The following is a description of a gene set: species: Homo sapiens We investigated at which stage of maturation commitment to a stable Foxp3-expressing phenotype takes place. We assessed stability of Foxp3 expression in thymic Foxp3+ Treg subsets of different maturity, defined by CD24 expression. Next we compared gene expression profiles of Foxp3+ Treg subsets (+) of different maturity (24lo, 24int, 24hi) and could identify a set of genes that were specifically up or downregulated in Foxp3+ Tregs, but not in Foxp3- conventional T cells, in a maturation-dependent manner. Genes up-regulated in CD42 high cells from thymus: T reg versus T conv. from publication Toker A, Engelbert D, Garg G, Polansky JK, Floess S, Miyao T, Baron U, Düber S, Geffers R, Giehr P, Schallenberg S, Kretschmer K, Olek S, Walter J, Weiss S, Hori S, Hamann A, Huehn J (PMID 23420886) Human Gene Set: GSE42021_CD24HI_TREG_VS_CD24HI_TCONV_THYMUS_UP, and this is the list of marker genes: COMMD1, SAMM50, PNPLA2, TMEM179B, EIF3K, MCM10, PPFIA4, MAP3K1 (mitogen-activated protein kinase kinase kinase 1), SENP3, NAXE, ACTB, ANAPC11, NR1H3, PRKAB1, STOML2, NDUFS3, RPP25L, DDX27, SNAPC2, PCSK7, REX1BD, LSR, RAB8A, PRPF31 (NCBI Gene Id 6106), CDC45, FES, NMI, FKBP8, TENM1, LRP1, CIAO1, TMEM126A (transmembrane protein 126A), PLEKHO1, UBXN1, HCN2, LEMD2, SSNA1 (SS nuclear autoantigen 1), ADD1, ASXL1, CDC37, PTCD2, CYBA, GSTT2, SMDT1, HIKESHI, CD52, NFIC, TLE5, RBM42, NLN, ETFB, RING1, SEMA4A, PSEN1, C3AR1, CHD8, UBE4B, GNAS, CAPNS1, MRAS, RGL2, POLR1D, ATP7A, UQCRC1, TP53, HSD17B7, PROM1, TEN1, FABP3, INTS3, ADPRM, LY86, CCR2, ATP5PO, ISYNA1, CDK2AP2, ERP29, REEP5, DYNLL1, IFI30, TPK1, AKT2, PPIB, HRAS, IGFBPL1, HTR1B, MAPK3, MEP1B, DFFA, ECH1, NELFE, PNKP, RPL28, NUBP1, PRKCSH, TAF11, CLTA, RAD50, ALDH3A2, VPS72, FLCN, SLC27A1, C1QB, BUD31 (BUD31 homolog), NCBP2AS2, ECHS1, PEX6, ATP5MG (NCBI Gene Id 10632), STAU1, MAN2B1, AURKAIP1, HOXC5, RPS23, CIDEC, MAF1, COMMD2, ING4, MRPL44, CEP89 (centrosomal protein 89), NDST2, PPP1R14B, RNASEH2A, LRP10, FBXW4, ZFYVE19, MAST3, AMMECR1L, ANGEL2 (NCBI Gene Id 90806), IL16, MKNK2, VAMP8, CEP250, ARHGAP45, RAD1, CSNK1G2, TCF25, EIF3L, PPP1R21, PTS (6-pyruvoyltetrahydropterin synthase), CD93, PDHA1, SMAD5, ARX, EIF2B5, PSMB6, PAFAH1B3, DUS1L, ALDOA, TMEM259, MXD4, MRPL4, HSF1, RPS6KB2, XRCC2, SESN1, TXNIP, ZDHHC9, TYMP, GRN, CTSA, CRCP, EIF3G, CLPP, SLC38A10, ESRRA, ENO1, NSUN2, PTOV1, CTSE, SETDB1, COLGALT1, ATM, DAD1, MRPS12, NME6, COPE, RBM10, RSRP1, ATP6V0E1, ZNF808, SCAMP2, RPL19, RPS5, PCBP4, NBR1, LMAN2, GATD3, BAK1, PRKCD, XAB2, FOXO3, SART3, CLPX, RERE, CD99, ARHGDIA, WBP11, NDUFB8, TFIP11, PAM